Given this list of marker genes Slc14a1, Slc5a1, Pdpn, Aqp7, Aqp8, Aqp6, Slc4a11, Aqp9, Aqp4, Aqp2, Aqp1, Aqp3, Aqp5 (aquaporin 5), Aqp11, Mip, here is a description of the gene set: Enables the transfer of water (H2O) from one side of a membrane to the other. Mouse Gene Set: GOMF_WATER_TRANSMEMBRANE_TRANSPORTER_ACTIVITY studied in species Mus musculus